Given this list of marker genes IP6K2, IP6K3 (inositol hexakisphosphate kinase 3), PPIP5K2, IP6K1, PPIP5K1, here is a description of the gene set: studied in species Homo sapiens Human Gene Set: GOMF_INOSITOL_1_3_4_5_6_PENTAKISPHOSPHATE_KINASE_ACTIVITY Catalysis of the reaction: ATP + 1D-myo-inositol 1,3,4,5,6-pentakisphosphate = ADP + diphospho-1D-myo-inositol tetrakisphosphate. The isomeric configuration of diphospho-1D-myo-inositol tetrakisphosphate is unknown.